The following is a description of a gene set: from publication Cui A, Huang T, Li S, Ma A, Pérez JL, Sander C, Keskin DB, Wu CJ, Fraenkel E, Hacohen N (PMID 38057668) Genes positively differentially expressed in cell type: Macrophage upon treatment with cytokine: IL-15 in mouse lymph nodes in vivo. Cytokines mediate cell-cell communication in the immune system and represent important therapeutic targets. A myriad of studies have highlighted their central role in immune function, yet we lack a global view of the cellular responses of each immune cell type to each cytokine. To address this gap, the authors created the Immune Dictionary, a compendium of single-cell transcriptomic profiles of more than 17 immune cell types in response to each of 86 cytokines (>1,400 cytokine-cell type combinations) in mouse lymph nodes in vivo. A cytokine-centric view of the dictionary revealed that most cytokines induce highly cell-type-specific responses. For example, the inflammatory cytokine interleukin-1β induces distinct gene programmes in almost every cell type. A cell-type-centric view of the dictionary identified more than 66 cytokine-driven cellular polarization states across immune cell types, including previously uncharacterized states such as an interleukin-18-induced polyfunctional natural killer cell state. studied in species Mus musculus Mouse Gene Set: CUI_MACROPHAGE_IL15_RESPONSE_UP, and this is the list of marker genes: Rnf19b, Ms4a4c, Bach1, Tor1aip1, Cnn3, Nras, Slfn5, Trim56, Marcks, Atad1, Junb, Ifitm3, Fas, Ifi44, Msr1 (NCBI Gene Id 20288), Rnf213, Dab2, Cebpb, Tfec, Tnip3, Pirb, Pphln1 (periphilin 1), Prpf31, Plek, Ifih1, Parp12, Max, Wfdc17, Vamp3, Idnk, Mefv (Mediterranean fever), Cxcl9, Ddx24, Cacybp, Usp15, Slc31a2, Spi1, Fth1, Tnfaip3, Il15ra, Gna13, Tap1, Eif4a1, Ccl8, Nt5c3, Sco1, Jpt1, Nfkbiz, Rigi, Strap (serine/threonine kinase receptor associated protein), Prkx, Ccl4, Mlkl, Csf3r, Lrch3, Il33, Il1rn, Lpar1, Steap4, Snx10, Psmb8, Ogfr, Runx1, Mtdh, Pmaip1 (NCBI Gene Id 58801), Stat2, Tent5a, Zfp281, Cebpd, Clec4n, Gtpbp4, Phf11b, Serpina3g (serine (or cysteine) peptidase inhibitor, clade A, member 3G), Ifitm2, Trafd1 (NCBI Gene Id 76301), Denr, Smchd1, Optn, Psme3, Fcgr4, Trib1, Zyx, Cers6, Txn1, Arl4a, Fgl2, Rnf4, Oasl1, Chmp4b, Cdc42ep2, Dr1, App, Herc6, Ptbp3, Bzw1, Srsf5, Hspa9, Gnb4, Ccl9, Sap30, Cggbp1, Sdc4, Il10ra, Cited2, H3f3b, Atp6v1b2 (NCBI Gene Id 97492), Ppp1r15b, Csrp1, Gbp2b, Mon2, Acod1, Sppl2a, Rap2c, Slfn8, Ube2s, Vcam1, Rcc1, Stx11, Ifi207, Ranbp1, Arpc2, Bzw2, Il1a (NCBI Gene Id 16175), Sgcb, Fubp1, Atp11b, Rin2, Slc11a2, Txnrd1, Eef1e1, Mt1 (NCBI Gene Id 17748), Ccl12, Azi2 (NCBI Gene Id 27215), Senp2, Usp18, Rtp4, Tap2, Ifi209, Bcl2a1a, Twf1, Mx1, Trim30d, Ifit3, Peli1, Tnfaip2, Xaf1, Rap1b, Adap2, Samd9l, Chchd1, Iigp1, Csrnp1, Sar1a, Casp8 (caspase 8), Stat3, Birc3, Dhx58, Ubxn4, Slfn2, Mospd2, Gbp7, Odc1, Tpm4, Cemip2, Gch1, Eif1a, Ms4a6d, Daxx, Gbp5, Btg1, Fcgr1, Ilrun, Cycs, Fcho2, Stk40, Etf1, Mt2, Sh3bp5, Apaf1, Dcp2 (decapping mRNA 2), Cdkn1a, Rmdn3, Rab20, Rnf114, Slc31a1, Cd14, Tor3a, Irgm2, Filip1l, Atp6v0b, Sod2, Xbp1 (NCBI Gene Id 52219), Rp2 (retinitis pigmentosa 2 homolog), Cxcl10, Elovl1, Cd40, Tlr4, Rapgef2, Srgn, Rhbdf2 (rhomboid 5 homolog 2), Trim30c, Tor1aip2, Stat1, Nampt, Rfc3, Sos1, Larp1, Slc15a3, Eif6, Cmpk2, Glipr2, Fnbp1l, Basp1, Zbp1, Nlrc5, Tcp1, Tra2a, Tle1, Pak1ip1, Hk3, Ccl7, Arf6, Irf8, Ube2d3, Ppp1r11, Ltv1, Trappc6b, Batf, Ube2f, Marchf5, Fcgr2b, Psme2, Hsbp1, Sp110, Ranbp2, Themis2, Batf3, Tnfrsf1a, 9930111J21Rik2 (NCBI Gene Id 245240), Metrnl, Mapkapk2, Tmed1, Parp14, Clec2d, Dusp2, Arfgef1, Homer1, Csf2rb, Ccl5, Sp100, Riok3, Jaml, Ccdc71l, Irf5, Smarce1, Adam9, Cldnd1, Il4ra, N4bp1, Thoc5, Gbp4, Evi2a, Cd164, Gbp9, Plekho2, Helz2, Myd88, Prpf38a, Irgm1, Phf11d, Ikzf1, Pi4k2a, Agfg1, Car13, Litaf (NCBI Gene Id 98032), Il1b, Casp1 (caspase 1), Rassf4, Naa25, Zfp800, Slfn9, Parp9, Fam241a, Fmnl2, Hbegf, Tpp2 (tripeptidyl peptidase II), Tspo, Ccl2, Mmp13, Snx2, Serpina3f, Gbp8, Lrrc59, Gja4, Diaph1, Tmem140, Hck, Fcer1g, Mmp14 (matrix metallopeptidase 14 (membrane-inserted)), Cd274, Lap3, Tmod3, Cxcl16, Ikbkb, Ifi47, Cd209a, Lilrb4b, Gbp3, Gadd45b, Saa3, Ifi211, Rock1, Tmbim6 (transmembrane BAX inhibitor motif containing 6), Gbp2, Dck, Casp4, Ubd, Ccdc25, Ist1, Glrx, Irf1, Marchf1, Stxbp3, Yme1l1, Ifi213, Lgals9, Gatm, Socs3, Ikzf2, Fndc3a, Hspa8, Marcksl1, Rbms1, Ywhag, Nae1, Crybg1, Treml2, Tpst1, Parp10, Ifit2, Cyb561d2, Ms4a6c, Lnpep, Lcp2, Tuba1c, Tiparp (NCBI Gene Id 99929), Inpp5b, Sting1, Rab8b, Utp6, Ms4a6b, Cp, Hspa5, Ctsc, Usp25, Tax1bp1, Slamf8 (SLAM family member 8), Samhd1, Eif2ak2, H2-T23 (NCBI Gene Id 15040), BC005537, Actg1, Socs1, Fgr, Znfx1, Psmb10, Dram1, Psmb9, Rnf149, Tcea1, Calhm6, Tgtp2, Etv6, Oasl2, Dnajc21, Sp140, Atf3, Scimp, Vta1, Anxa7, Nod1, Cd38, Bcl3, Bcl2a1b, Ptpn1, Ifit1, Mvp, B4galt3, Ybx3, Xdh, Batf2, Txndc17, Klrk1, Noc4l, Ifi203, Ifrd1 (NCBI Gene Id 15982), Tma16, Zup1, Arf4, Ifi208, Plekhf2, Ascc3, Hnrnph2, Osgin1, Brd2, Procr, Aida, Spred1, Katna1, Lacc1, Ifi205, Trim30a, Ifi204 (interferon activated gene 204), Ncoa7, Irf7, Pml, Lyn, Rab11a, Dnaja2, Ifi35, Sdcbp, Ncl, Clic4, Gadd45g, Adar, Dtx3l (deltex 3-like, E3 ubiquitin ligase), Pik3cd, Nuak2, Psma3, Hat1, Pim1, Isg15, Acbd3, Gk, Ppp2ca, Sirpa, Pnp, Hilpda, Zcrb1, Ifi206, Tmem183a, Il27, Rars1, Icam1, Pak2, Klf6, Etnk1, Cpne3, Vbp1, Il15, Unc50, Hdac9, Vav1, Psme1, Gbp6, Lipg, Mbd2, Igtp, Ppa1, Crem, Tlk2, Mndal, Mdm4, Cd74, Nmt2, Gtf2b, Fcgr3, Rsad2